Given this list of marker genes CXADR, H4C13 (NCBI Gene Id 8368), PODXL, ADRM1, ZFPL1, SPEF1, ACOX3, THOP1, GDAP1L1, CES1, TICAM1, ZNF7, EIF1B (NCBI Gene Id 10289), MAP3K12, CRABP1, ABO, NUDT13, OPLAH, PSMD5, PTX3, ACYP2, KLHL1, PRIM2, SMPDL3A, ST20, TONSL, NMUR1, MAST4, DAXX, NAMPT, RPAP1, NPAS1, HSF2, C10orf95, HMCES, FABP6, ANKRD40, PHGDH, SAMD4B, BPNT1, GPR137B, TARS2 (NCBI Gene Id 80222), TRAF3IP2, PARVB, PLEKHA4, H2AC15, PEX10, OPRD1, IL37, ZKSCAN5, LRRC14, CHGA (chromogranin A), DGKQ, NPY4R, KLHL12, KHDRBS3, ZNF34, RPL23AP32, GSG1, ZNF696, DHX8, PGK2, CYREN (cell cycle regulator of NHEJ), RAP1B, ACTR3B, BAHD1, PRICKLE3, PIGF, FCF1, SOX18, ASCL2, UCP1, TMEM214, LYRM1, F10, S100A7, ADAMTSL2, CDK16, ZNF174, SMS, LIG3, FRK, ANGPTL3, NR0B1, KIR2DL3, KRT81, NRIP2, NBEAL2, RNASEH1, SLC22A1, NDP, LILRA4, NR5A1, TSSC4, MRTO4, RBM17, LTK, LCN1, CA5BP1, PDE1B, IMPDH1, IFNW1, NECAB3, KANK3, VCP, DBN1, TCAP, CDC20, SIGLEC9, FABP3, VPS33B, CYP2U1, FOXL1, GTDC1, POLDIP2, ATAD3A, RCL1, VCX2, TSR2, CARD9, TGDS, EEF1A2, MEGF8, PTPN13, OR7E24, ANKS1B, PFKFB3, KCNN4, TSPAN31, KAZN (kazrin, periplakin interacting protein), CYRIA, CNN1, GPT, ASTN2, PRDM12, RAB9BP1, HSD11B1, TTPAL, SUPV3L1, BUB1B, TERF2IP, GYPE, SRPRB, NHERF2, PTCD1, GAMT, ACOT7, HOXD12, POM121, SHARPIN, MPST, CISH, ENTREP2, ZDHHC11, VAPB, SSTR5, SH3GL1, MAP3K13, CCNE1, TMEM132A, LRCH1 (NCBI Gene Id 23143), ORC1, TSFM, CHTOP, TUBA3D, CCL27, PPY2P, PYGO1, NEDD4L, LTB4R, HEXA-AS1, DKK4, RBM19, NUDT6, NDOR1, PPP2R3B, PLEKHJ1, PDIA5, LTBP4, VAMP4, SLC7A7, C1orf50, NME3, PALM, TMED3, NPPC, HCN2, PGP, AEBP1, GDNF, COMMD4, ZNF639, DNAI1, TFR2, FAM182A, AQP9, PAWR, here is a description of the gene set: Leishmania major infected human dendritic cells (DCs) exhibit a marked induction of IL-12 ultimately promoting a robust Th1-mediated response associated with parasite killing and protective immunity. In this study, we utilized Affymetrix Genechips to globally assess the host cell genes and pathways associated with L. major infection during early infection (2, 4, 8, and 24 hrs) in human myeloid-derived DCs. Bioinformatic analyses of the hybridized microarray chips identified genes, represented by 848 unique probe sets, which, when compared to uninfected samples were observed to be significantly differentially expressed by one-way ANOVA. Altogether, the data provide a genome-wide perspective on the transcriptional influences Leishmania species exert within human DCs during early infection, and provides a platform for further investigations toward functionally characterizing candidate genes of importance to the IL-12 based immune response to infections. In the current study, we further investigate the L. major infected DC transcriptional during early time points after infection via microarray analysis. from publication Favila MA, Geraci NS, Zeng E, Harker B, Condon D, Cotton RN, Jayakumar A, Tripathi V, McDowell MA (PMID 24808365) species: Homo sapiens Human Gene Set: GSE42088_2H_VS_24H_LEISHMANIA_INF_DC_DN Genes down-regulated in dendritic cells infected by Leishmania major: 2h versus 24h.